The following is a description of a gene set: Genes down-regulated in comparison of lineage negative versus neutrophils. from publication Konuma T, Nakamura S, Miyagi S, Negishi M, Chiba T, Oguro H, Yuan J, Mochizuki-Kashio M, Ichikawa H, Miyoshi H, Vidal M, Iwama A (PMID 21540074) species: Homo sapiens Each fraction of mouse hematopoietic cells was purified by cell sorting from bone marrow of 8-week-old C57BL/6 mice, and its gene expression was analyzed. Human Gene Set: GSE27786_LIN_NEG_VS_NEUTROPHIL_DN, and this is the list of marker genes: ITPK1 (NCBI Gene Id 3705), SNAI1, PRLR, ZBTB7A, TPST2 (tyrosylprotein sulfotransferase 2), SLC25A11, DCTN1, TAS1R3 (NCBI Gene Id 83756), VCAN, MFSD4B, CPEB4, NFKBIE, KLC1, MORC3, STX12, HUNK, ABCA7 (NCBI Gene Id 82843), IL20, OSTM1, PTGDR, SFMBT2, EID3, SUPT4H1, TMX4, GAB2, PGS1, GPR107, KRAS, CDH16, BMP15, KLHL9, PTPN12, BABAM2, CERT1 (ceramide transporter 1), HLA-E, HOXD4, RILPL2, MPND, ATP6V1F, BASP1, ADAMTSL4, CMTM6, IER3IP1, PPP2CB (NCBI Gene Id 5516), CDKL4, TRDMT1, CHMP1A, CHFR, ZFAND5, SLC34A1, SAP30, KMT2D, PRKAB1, SLC16A6 (solute carrier family 16 member 6), SH2B2, INPP5E, RAG1, FAM111A, SNF8, SLC30A1, MPP3, HBP1, CNIH4, ADAMTSL3, HEATR6, LRP10 (NCBI Gene Id 26020), SERPINB1, SLC12A1, EZH1, ZC3HAV1, DLGAP2, ATP8A2, RARG, TRAM2, LRRC74A, PGGHG, RC3H2, HAS2, INPPL1, ATOX1, RPP25, TRIM8, KRT78 (NCBI Gene Id 196374), CREB3L3, MTMR6, DHRSX (NCBI Gene Id 207063), MIEN1, TACC1, DCAF11, GRB2, STX5, SP1, MED17, MAF1, ARL3, MEF2B, AKT2, EMC2, MVB12B, EML2, KRT80, ARL2BP, ATP6V0A4, GJA4, GPER1, ERRFI1, VCF1, MUC4, ALPI, KCTD11, NRAP, ATXN1L, SOS2, ZYG11B, PHF1, IL1RAP, CITED2, VPS9D1, TRAF3, PXYLP1, FBXO42, TRIM39, SHARPIN, UPF3A, PABPC1L, RBPJ, CFLAR, FAM13B, EMB, MCF2L, CCNL2 (NCBI Gene Id 9613), SLC17A7, VPS28, WNK2, TIAM2 (TIAM Rac1 associated GEF 2), SPATA13, NSD3, C11orf71, CDK9, TBC1D10C, NRG2, C14orf119, EPHX3, RAF1, GSK3B, PLEKHM2, CCN3 (NCBI Gene Id 4856), LRCH3 (NCBI Gene Id 84859), ELOVL1, GALE, CHAC1, FAM120B, BTK (Bruton tyrosine kinase), HECA, TXNDC9, NFAT5, COL11A2, RPRD1A, CAMK1D, TBPL1, EMILIN2, NIT1 (NCBI Gene Id 4817), CRAT, ABRACL, ZNRF1, ADIPOR2, SLC17A9 (NCBI Gene Id 63910), TMEM104, S100A5, TMEM30A, SNAPC5, MPP1, AGTPBP1, DDR1, NCK1, TCIRG1, ACLY, B3GNT2, DNAJC1, ANAPC2, USE1, C9orf78, MRAP2, MMP24, B3GAT3, CIC, ITFG1, OR7C1, HOXD13 (NCBI Gene Id 7859), ATG2A, MLPH, CAST, PLEC, SUSD6, RNF185, SLC22A14, FAM217B, KCND1, TRIM5 (NCBI Gene Id 85363), ATP5ME (NCBI Gene Id 521)